Given this list of marker genes SH3TC2, SBF2, ALS2, ATP13A2, EDN1, GIPC1, RILPL1, NOTCH2NLC, LRP12, PLCB4, GNAI3, FRAS1, GAA, here is a description of the gene set: studied in species Homo sapiens Reduced strength of the tongue musculature, resulting in difficulties moving the tongue and possible accompanied by dysarthria or dysphagia. Tongue muscle weakness Human Gene Set: HP_TONGUE_MUSCLE_WEAKNESS